Given this list of marker genes YPEL4, ZKSCAN1, IL18BP (NCBI Gene Id 10068), MMP19, SEMA6D, VEZF1, DCTN4, QKI, URI1, ARL4C, SOX11, ZBTB7A, DCUN1D3, CACNA1D, HOGA1, GAN, DLL1, ARIH1, GALE, RPS6KA3, DHX15, C11orf87, RIPOR1, FAT2, AGO1, CYB561D1, GATAD2B, PAFAH1B1, LRRC37A6P, PAFAH1B2, PTPRG, TNRC6B, SYNE1, DPYSL5, DAZAP2, MBOAT2, MKRN1, DYRK1A (dual specificity tyrosine phosphorylation regulated kinase 1A), TLK2, MTDH, BAZ2A, NEDD4L, CDKN1B, ZFAND5, CLOCK, LRRC31 (leucine rich repeat containing 31), FMNL3, SEC62, FAM185A, RNF43, GIGYF1, MDGA2, OGT, NPAS2, BAZ1B, LARP4B, STK4, JPH4, UBE2Z (NCBI Gene Id 65264), CS (citrate synthase), PPP1R7, PCDH17, XRN1, EPB41, BICD2, CAPRIN1, ARHGEF12, NANOS1, IKZF4, LRP8, SUV39H1, BBOF1, DNAJC16, SLCO3A1, SP1, SKIDA1, TRIM9, BTBD3, KAT6A, ITPRID2, EFNB1, SYT1 (synaptotagmin 1), MAP3K7, EPHA7 (EPH receptor A7), SLC6A15, BCOR (NCBI Gene Id 57686), COX11, NR4A2, MTMR4, here is a description of the gene set: Human Gene Set: AGGCACT_MIR5153P Genes having at least one occurence of the motif AGGCACT in their 3' untranslated region. The motif represents putative target (that is, seed match) of human mature miRNA hsa-miR-515-3p (v7.1 miRBase). studied in species Homo sapiens